The following is a description of a gene set: The regionalization process that divides an organism or part of an organism into a series of semi-repetitive parts, or segments, often arranged along a longitudinal axis. studied in species Mus musculus Mouse Gene Set: GOBP_SEGMENTATION, and this is the list of marker genes: Nog, Myf6, Nrarp, Kat2a, Mib1, Nrp1, Cripto, Xrcc2, Mesp1, Pcsk6, Dmrt2, Frs2, Hes7, Fzd5, Lfng, Mafb, Ednra, Tdrd6, Foxa2, Irx3, Med12, Dll3, Taf10, Foxf1, Tcap, Abi1, Foxc1, Foxc2 (NCBI Gene Id 14234), Pofut1, Bmp4, Mllt3, Ripply1, Tcf15, Shh, Bmpr1a, Irx1, Zic3, Lama5, Prkdc, Irx2 (NCBI Gene Id 16372), Gdf3, Chrd, Wnt3a, Tbx3, Sfrp2, Tmed2, Six1, Lrp6, Cdx2, Tdrd7, Lef1, Lhx1, Dvl2, Acd, Myf5, Tdrkh, Ppp2r3a, Notch1, Sema3f, Poglut1, Mesp2, Kdm6a, Nkx3-1, Wt1, Meox1, Tbx6, Egr2, Tbx18, Foxb1, Otx2, Nle1, Crb2, Epb41l5, Zic2, Plxna2, Nrp2, Smad3, Tdrd5, Msgn1, Palb2, Rbpj, Wnt5a, Nckap1, Ror2, Dkk1, Neurog1, Mtf2, Tdrd1, Sema3c, Tasor, Smad4, Cdx1, T (brachyury, T-box transcription factor T), Ifitm1, Dll1, Cobl, Sfrp1, Pcdh8, Hes5, Ttn, Trp53, Hoxa2 (NCBI Gene Id 15399), Tcf7l1, Sema3a, Psen1, Pax1, Pax3, Ep300, Aldh1a2, Zeb2, Osr1, Tifab, Meox2, Ripply2, Pld6, Axin2, Psen2, Atm